The following is a description of a gene set: species: Homo sapiens Human Gene Set: HP_SHALLOW_ACETABULAR_FOSSAE Shallow acetabular fossae, and this is the list of marker genes: SMARCAL1, IFIH1, COG1, RNU4ATAC, TBX4, UFSP2, RAB23, GNPTAB, PHLDB1, HOXA11, TONSL